Given this list of marker genes Arih1 (ariadne RBR E3 ubiquitin protein ligase 1), Rgs5, Lysmd3, Il7, Edil3 (EGF-like repeats and discoidin I-like domains 3), Gm5916, Prkar1a, Cpsf6, Aak1, Mbnl1, Lancl2, Stmn2, Slc30a1, Srr, Akap5, Gm14434, Inpp5f, Emp1, Zfp608, Kdm7a, Bivm, Rnf145, Cdc37l1, Il17a, Gclc, Etnk1, Nipbl, Zfp942, Myo1e, Pcgf3, Gng2, Cnot6, Stk17b, Satb1, Vps37a, Abcc4, Cplx1 (complexin 1), Amotl1, Zfp318, Rasa1, Cyrib, Atp1b4, Camk2d, Hecw1, Rgs17, Nedd4l, Glyr1, Rmnd5a, Angel2, Zdhhc21, Lox, Mecp2, Shcbp1l, Neurod4, Mrps2, Baz1b, Lrp6, Chic2, Dach2, Suz12, Adss2, Unc13c, Esr1, Slc25a21, Zfx, Gfpt1, Nr1d2, Rpgrip1l, Mageh1, R3hdm1, Atp10a, Nectin3, Abcg3, Caprin1, Arl5a, Pias2, Ints2, Vwc2l, Hecw2, Apol7a, Asb3, Ror1, Abcc9, Sbno1, Ccne2, Prkci, H2ap, Pcsk5, Fbxo38, Gulp1, Mafg, Fhod3, Grpel2, Zfp148 (NCBI Gene Id 78647), Mcl1, Lpp, Gask1b, Clec2i, Phip, Fnbp1l, Usp1 (NCBI Gene Id 230484), Gm14308, Cyp24a1, Tnrc6a, Cip2a, Rbpms2, Prkaa2, Cdc42se2, Ankrd12, Ugcg, Prnd, Anxa7, Spsb1, Pabir2, Fads1, Map1b (microtubule-associated protein 1B), Ccl20, Zfp1004, Cdyl, Shprh, Cpne3, Aldh5a1, Samd8, P2ry10b, Zfp946, Fgf18, Pds5b, Nampt, Prdm8, Jag2, Zc2hc1a (NCBI Gene Id 99818), Tle1, Txnl1, Pyurf, Hnrnpm, Arfgef1, Cbfb, Dennd4a, Neu3, Rp2, Nbr1, 1600014C23Rik (RIKEN cDNA 1600014C23 gene), Tcf7l2, Vsig4, Vegfc, Tmx3, Zfp597, Nrk, Tmem184c, Plekhh2, Rgs7, Nedd4, Gng10, Slk, Sox7, Herc3, Bnc1, Septin12, Ttc9, Prtg, Spred1, Tpp2, Map2k1, Ankrd29, Fgd4, Fgf12, Ptgs2, Galnt2, Prl8a2, B3galt6, Mmd (NCBI Gene Id 69866), Mybl1, Arl4a, Upk1b, Zscan29, Dip2c, Mynn, Crisp4, Taf2, Rnf13, Tgfbr3, Fut9, Slc2a13, Robo2, Slc35f1, Pcdh20, B3gnt5, Bcat1, Blcap, Rfx7, Nfat5, Hlf, Folh1, Slc45a3, Man1a, Nek7, Col1a2, Ncoa2, Edem1, Gm2026, Zfp345, Qser1 (NCBI Gene Id 99003), Ndfip2, Kdm6a, Tshz3, Ap1s3, Ctdspl2, Fign, Kras, Arhgap26, Hipk3, Rab2a, Zbtb11, Mctp1, Ltn1, Hycc2, Pde7a (phosphodiesterase 7A), Zeb2, Dlg1, Angpt1, Ccdc117, Mrps30, Col4a3, Mreg, Zbtb44, Katnal2, Rit1, Slc39a8, Bag4 (BCL2-associated athanogene 4), Mpz, Ppp1cb, Dhx57, Zfp944, Lamp2, Slco5a1, Spry4, Rab32, Pate5, Ythdf3, Fgfbp3, Pip4p2, Gm4724, Nkain2, Lhx8, Pank3, Tmed7, Sec23a, Elmod2, Fam13c, Nmu, Mettl9, Ttc5, Unc80, Stac, Taok1, Tmeff1, Psma2, Kif3a, B3galnt1 (NCBI Gene Id 26879), Jazf1 (JAZF zinc finger 1), Tmem170b, Atp2a2, Sun1, Lnpk, Map4k4, Fgfr1op2, Akap6, Smndc1, Stag2, Col19a1, 1810037I17Rik, Ccdc38, Arid4a, Ociad1, Chl1, Smc2, Pou3f2, Zfp871, Steap2, Ufl1, Rsf1, Gipc2, Ppp6r3, Fbxw11, Csmd3, Ywhae, Nsg1, Klhl13, N4bp2l2, Cxcl2 (C-X-C motif chemokine ligand 2), Fam133b, Uox, Limch1, Ndnf, Zfp994, Nup98, Prdm1, Ptprn2 (NCBI Gene Id 73860), Cpne4, Pof1b, Akap1, Lamc1, Hrh3, Bmp15, Rps6ka3, Mapk1, Tbxas1, Katnbl1, Bet1, Rp1l1, Lpar4, Vat1l, Foxn2, Cfl2 (NCBI Gene Id 12632), Cpeb2, Tank, Creb5, Prpf40a (NCBI Gene Id 75419), Ppargc1b (NCBI Gene Id 170826), Bmp5, Cd164, Tram1, Abi1, Slain2, Crk, Adamtsl1, Ptprb, Ncbp3, Ube2e3, Arx, Sf3b1, Atp2b1, Tmed8, Rfx3, Frmd6, Clec4d, Bloc1s6, Greb1, Irak4, Tardbp, Usp3, Nup35, Spink11, Kcnq5, Nabp1, Lrrc57, Akirin2, Zfp711, Trpc1, Car10, Notch1, Fmo9, Nrxn1, Ttc39a, Zfp799, Lair1, Tusc1, Osbpl3, Magi3, Ttc39b, Fzd1, Tmem196, Arhgap5, Ehf, Ap1ar, Bcor, Nipal1 (NCBI Gene Id 70701), Ccdc148, Lin28b (lin-28 homolog B), Sema3c, Acvr1c, Rnf168, Shisa6, Pdlim5 (NCBI Gene Id 99766), Zcchc2, Gria3, Mysm1, 1600012H06Rik, Zbtb18, Ctf1, Kcna4, Nt5dc1, Inpp4a, Ino80d, Otud4, Tnpo1, Rc3h1, Serinc3, Smap1, Dusp16, Tmem167, Radil, Set, Nfatc1, Spock3, Ptpn13, Gm14295, Rnf38, Tnrc6b, Bub1, Gas7, Farsb, Shank1, Tlk1, Rab1a, Xk, Stxbp5, Glcci1, Usp15, Rnf11, Rtp2, Atf2, Foxr2, Smad9, Actr1a, Clec2g, Hsf2, Tmem65, Slc35e3, Gabra1, Skil (NCBI Gene Id 71615), Gm4871, Prl5a1 (prolactin family 5, subfamily a, member 1), Nlgn1, Sult1d1, Otulinl, Vegfa, Scn9a, Manea, Khdrbs1, Pdzrn3, Mier3, Kcnb2, Tex16, Nts, Rundc3b, Sri, Ncor1, Tmem70, here is a description of the gene set: from publication Chen Y, Wang X (PMID 31504780) Mouse Gene Set: MIR_30F Genes predicted to be targets of miRBase v22 microRNA mmu_miR_30f in miRDB v6.0 with MirTarget v4 prediction scores > 80 (high confidence targets). studied in species Mus musculus